Given this list of marker genes ARID1A, AHNAK, MDK, CAMK2G, GABPB2, KCNIP2, EPHB2, LDB3, ATXN7L2, GRK5, EIF4G2, STX6, ZNF503, LBX1, CRTC2, NR0B2, ZEB1, HCRTR1, TNNI2, ZCCHC24, TCF7L2, ASCL2, DUSP8, PTPRF, KDM4A, SDHAF2, TPM3, INAVA, ZNF362, PRELP, HERC4, ZFP91, KCNC1, CPSF7, LHX4, YARS1, PLCB3, TIAL1, PPOX, PRDM16, BCL9, PRMT6, OTUB1, DNAI4, LMNA, RFX5, NEURL1, SPINDOC, ATP2B4, SHC1, MOV10, RNF220, MYBPC3, MIR9-1HG, NRAS, POGZ, ARFIP2, CREM, HDAC1, BRDT, MACO1, TRIM8, MYOZ1, TSSK3, SYT11, SZRD1, TIMM10B, FHL3, P4HA1, ZNF687, ENSA, EMX2 (NCBI Gene Id 2018), PHF13, NR1H3, FKBP2, BDNF (NCBI Gene Id 627), SESN2, RNF2, PHC2, GTF2H1, UPF2, LRRC20, MARCKSL1, PIP5K1A (NCBI Gene Id 8394), PBX1, PPM1J, ROR1, HPCA, RPRD2, ZNF496, RPL5, EFNA1, ADGRB2, TMEM109, TRIM46, NEUROG3, CELF1, STX5, DCHS1, POU2F1, ZNF644, PAX6, NFYC, PIK3AP1, SCUBE2, CAPRIN1, SSBP3, PTPRJ, JUN, ATP1A1, FDPS, DENND2B, DNAJB12, NCDN, GFRA1, TLX1, CUL2, E2F8, PLA2G2E, PATL1, FAM53B, KANK4, KCNQ1DN (KCNQ1 downstream neighbor), KCNT2, CSDE1, PLEKHA6, PHF21A, RHOG, SERINC2, SYT7, TOR1AIP2, HNRNPF, MLLT10, NPPA, PTPN5, LIN28A, WAC, ADAMTSL4 (ADAMTS like 4), ZBTB17, KCNQ4, ENTREP3, CASQ1, NT5C1A, XPR1, ASTN1, SLC2A1, MDM4, GALNT2, THRAP3, POLR3GL (NCBI Gene Id 84265), RERE, SDE2, HNRNPR, MIER1, SETDB1, OGA, ADCY10, UBR4, LCK, ZNF143, COA7, CA14, RTN4RL2, CTNNBIP1, OTUD7B, RCOR2, PLK3, HMGN2 (NCBI Gene Id 94860), UBE4B, TCEA3, APBB1, FNBP1L, PIAS3, MPC2, CNN3, HPS5, CLSTN1 (NCBI Gene Id 22883), HSD11B1, TRIM33, ARHGEF2, PROX1, CTNND1, CKS1B, KRTCAP2, EPHA2, F2, GRIK3, SMG7, DDX50, PPRC1, ZC3H11A, CCDC24, PACSIN3 (NCBI Gene Id 51165), here is a description of the gene set: species: Homo sapiens Genes having at least one occurrence of the motif GGGGAGGG in the regions spanning 4 kb centered on their transcription starting sites. This matches the MAZ transcription factor binding site V$MAZ_Q6 (v7.4 TRANSFAC). Human Gene Set: MAZ_Q6